Given this list of marker genes DEFB136, DEFB108A, DEFB113, DEFA3, env, DEFB108B, PRSS2, DEFB103A, DEFB124, DEFB112, DEFB107A, TLR2, DEFB117, DEFB128, DEFB105A, DEFB123, DEFB125, DEFB129, DEFB118, DEFB4A, TLR1, DEFB130A, DEFA4, DEFB121, DEFB110, CCR2, DEFA5, DEFB130B, CD4, DEFB104A, DEFB1, DEFB135, DEFB126, DEFA6, DEFB114, DEFB119, DEFB109B, ART1, PRSS3, DEFB134, DEFB132, DEFB116, DEFB115, DEFB106A (NCBI Gene Id 653667, defensin beta 106A), DEFB133, DEFB131A, DEFB127, CCR6, DEFA1, here is a description of the gene set: species: Homo sapiens part of: Antimicrobial peptides The defensins are a family of antimicrobial cationic peptide molecules which in mammals have a characteristic beta-sheet-rich fold and framework of six disulphide-linked cysteines (Selsted & Ouellette 2005, Ganz 2003). Human defensin peptides have two subfamilies, alpha- and beta-defensins, differing in the length of peptide chain between the six cysteines and the order of disulphide bond pairing between them. A third subfamily, the theta defensins, is derived from alpha-defensins prematurely truncated by a stop codon between the third and fourth cysteine residues. The translated products are shortened to nonapeptides, covalently dimerized by disulfide linkages, and cyclized via new peptide bonds between the first and ninth residues. Humans have one pseudogene but no translated representatives of the theta class.<br>In solution most alpha and beta defensins are monomers but can form dimers and higher order structures. <br><br>The primary cellular sources of defensins are neutrophils, epithelial cells and intestinal Paneth cells.Those expressed in neutrophils and the gut are predominantly constitutive, while those in epithelial tissues such as skin are often inducible by proinflammatory stimuli such as LPS or TNF-alpha.<br><br>Defensins are translated as precursor polypeptides that include a typical signal peptide or prepiece that is cleaved in the Golgi body, and a propiece, cleaved by differing mechanisms to produce the mature defensin. Mature defensin peptides can be further processed by removal of individual N-terminal residues. This may be a mechanism to broaden the activity profile of defensins.<br><br>Defensins have direct antimicrobial effects and kill a wide range of Gram-positive and negative bacteria, fungi and some viruses. The primary antimicrobial action of defensins is permeabilization of microbial target membranes but several additional mechanisms have been suggested. Defensins and related antimicrobial peptides such as cathelicidin bridge the innate and acquired immune responses. In addition to their antimicrobial properties, cathelicidin and several defensins show receptor-mediated chemotactic activity for immune cells such as monocytes, T cells or immature DCs, induce cytokine production by monocytes and epithelial cells, modulate angiogenesis and stimulate wound healing. Reactome Pathway: Defensins